The following is a description of a gene set: This event has been computationally inferred from an event that has been demonstrated in another species.<p>The inference is based on the homology mapping from PANTHER. Briefly, reactions for which all involved PhysicalEntities (in input, output and catalyst) have a mapped orthologue/paralogue (for complexes at least 75% of components must have a mapping) are inferred to the other species. species: Mus musculus part of: TCF dependent signaling in response to WNT electronically inferred by orthology from the curated human pathway Reactome Pathway: Degradation of AXIN, and this is the list of marker genes: Rnf146, Ubb, Psmd13, Psmb7, Psmc1, Psmd6, Psmc6, Axin2, Psmc5, Axin1, Psmb6, Smurf2, Psmd12, Psmb4 (proteasome (prosome, macropain) subunit, beta type 4), Psma6, Tnks2, Psma2, Psma4, Psmb5, Psma5, Psma1, Psmc2, Psmc4, Psma3, Psma7, Psmd1, Rps27a, Psmd7, Psmc3